Given this list of marker genes Trnp1, Nr6a1, Fam89b (NCBI Gene Id 66159), Psg21, Parp11, Dapl1, Sfmbt2, Ldb3, Gria2, Ap1g1, Cd37, Git1, Marf1, Psg17, Yif1b, Eya1, Adamts17, Krtap4-6, Krtap4-2, Phc2, Ptp4a1, Grik3 (glutamate receptor, ionotropic, kainate 3), Cyp4v3, Dagla, Atf6, Me3, Bbln, Prss32, Trp53inp2, Sftpa1, Cry2, Tnfsf13, St8sia6, Pklr, Vps25, Gm867, Bptf, Psca, Depp1, Igf2bp2, Xirp1, Gpr149, Iqsec3, Plpp6, Cyp2c55, Gjc3, Zmiz1, Dtna, Scn4b, Xylt2 (xylosyltransferase II), Gars1, Psg19, Trpc3, Reln, Psg22, Acer2, Khnyn, Tcte1, Wars1, Adcyap1r1, Limch1, St8sia3, Hnrnpu, Tbr1, Ppp4c, Arhgef2, Wnt1, Fbxw9, Psg26, Cp, Vash2, C2cd2l, Hpcal4, Ctsw (NCBI Gene Id 13041), Pmm2, Ttc9, Slc2a4, Ttc7, Ezh1, Fev, Slco1a5, Grb10, Shisal1, Tnfsfm13, Mbnl3, Lyl1, Slc26a5, Atxn1l, Dlg4, Atg10, Cntn4, Brpf3, Acsf2, Htra3, Stk35, Myef2, Dnajb13, Cdk6, Fam53c, Eri1, here is a description of the gene set: Genes predicted to be targets of miRBase v22 microRNA mmu_miR_6922_5p in miRDB v6.0 with MirTarget v4 prediction scores > 80 (high confidence targets). Mouse Gene Set: MIR_6922_5P from publication Chen Y, Wang X (PMID 31504780) species: Mus musculus